The following is a description of a gene set: Laminin interactions species: Homo sapiens Human Gene Set: REACTOME_LAMININ_INTERACTIONS, and this is the list of marker genes: COL4A2, LAMA3, NID2, LAMB3, COL4A5, LAMB1, COL4A3, ITGB1, LAMC1, ITGB4, LAMC2, COL18A1, COL7A1, ITGAV, ITGA2, COL4A4, COL4A6, LAMA4, LAMA1, ITGA6, NID1, COL4A1, LAMA5, ITGA7, HSPG2, ITGA3, LAMB2, LAMC3 (laminin subunit gamma 3), LAMA2, ITGA1